Given this list of marker genes PARP2, XRCC1, CHD1L (chromodomain helicase DNA binding protein 1 like), APLF, MACROH2A1, HTATSF1, CGAS, here is a description of the gene set: studied in species Homo sapiens Binding to a protein upon ADP-ribosylation of the target protein. Human Gene Set: GOMF_ADP_D_RIBOSE_MODIFICATION_DEPENDENT_PROTEIN_BINDING